The following is a description of a gene set: species: Homo sapiens Genes up-regulated in CD4 T cells: IL6 versus TGF beta and IL6. Human Gene Set: GSE21670_IL6_VS_TGFB_AND_IL6_TREATED_CD4_TCELL_UP from publication Durant L, Watford WT, Ramos HL, Laurence A, Vahedi G, Wei L, Takahashi H, Sun HW, Kanno Y, Powrie F, O'Shea JJ (PMID 20493732) STAT3, an essential transcription factor with pleiotropic functions, plays critical roles in the pathogenesis of autoimmunity. Despite recent data linking STAT3 with inflammatory bowel disease, exactly how it contributes to chronic intestinal inflammation is not known. Using a T cell transfer model of colitis we found that STAT3 expression in T cells was essential for the induction of both colitis and systemic inflammation. STAT3 was critical in modulating the balance of T helper 17 (Th17) and regulatory T (Treg) cells, as well as in promoting CD4+ T cell proliferation. We used chromatin immunoprecipitation and massive parallel sequencing (ChIP-Seq) to define the genome-wide targets of STAT3 in CD4+ T cells. We found that STAT3 bound to multiple genes involved in Th17 cell differentiation, cell activation, proliferation and survival, regulating both expression and epigenetic modifications. Thus, STAT3 orchestrates multiple critical aspects of T cell function in inflammation and homeostasis., and this is the list of marker genes: C3orf52, CREBRF, SLC66A1LP, FYB1, RPL12, LINC00189, FBXW8, GABRG1, GPR88, TRIT1, LBH, RPS25, STX17, COX7C, REG4, GABRB2, PITPNC1, DBI, PLIN3, ATP10A, THEMIS2, TPP2, PSMB1, SNRPE, MAN2A1, RASGRP2, ADSS2, IFITM2, RNF175, MICOS10, BAG3, PROX1, DGKA, ERP27, AAK1, PRKACB, RPL6, MIR30C1, UBASH3B, SNORD83A, NDUFV2, GPA33, PGGT1B, ACTL6A, EEF2KMT, LEF1, SCN10A, C1QBP, XYLB, CD48, RPS24, TEC, ADGRE1, GMFG, BCL9L, NOG, GLRX, SNORA55, SOD1, SYPL1, SLC20A2, RASGRF2, TUT4, COX6C, PACS1 (phosphofurin acidic cluster sorting protein 1), SLC39A10 (solute carrier family 39 member 10), RIPOR2, PDCD5, PYY, MGAT4A, RPS27, RPS27A, IFITM1, CELF2, ARHGEF11, UTP20, PLCL2, PAGE5, CCR7, RNF152, N6AMT1, SELL, TGFBR2, CXCL10, CRLS1, DYRK2, PEX7, TMEM272, SNORD41, PNO1, MAML2, SFPQ, TC2N, SIGLEC1, ATXN10, POLR1B, PAICS, BMP2K, SPG21, AGPAT5, ZNF507, PSMG2, SEMA3A, ADA2, PSMG4, HEBP1, COX16, RBFA, RPL23A, RCSD1, CFAP97, SULT1A2, TMEM37, ZYG11A (zyg-11 family member A, cell cycle regulator), MRPL3 (NCBI Gene Id 11222), NDUFB4, SGTB, STK38, MSR1, TMEM218, TRIB2, IFITM3, PLAC8, SPARCL1, SDK2, UQCRBP1, AOAH, RAB3GAP1, FUCA1, CD28, PHF7, ACTN1, MEF2A, GIMAP6, PRKCA, MDM4, MDS2, IL36A, ACY1, UBE3D, C16orf74 (NCBI Gene Id 404550), ATF6 (activating transcription factor 6), SDHC, OR1N1, RNU11, SPIRE2, USP3, LDLRAP1, CALB1, NLN, HSD17B11 (hydroxysteroid 17-beta dehydrogenase 11), UBR3, RAPGEF6, PFN2, SF1, FPGS (NCBI Gene Id 2356), C9orf72, CMTM7, GIMAP8, APBA2, IFNA5, ITGA6 (NCBI Gene Id 3655), CACUL1, MNT (NCBI Gene Id 4335), SERPING1, GCLC, GALR3, MLC1, MAS1L, NUAK2, ZNF800, SLC35E3, FCMR, RAB42, SULT1B1 (NCBI Gene Id 27284), CNIH2, CCDC85B, GTF3A, GIMAP2, NRIP1, NIT2, SLC36A2, CTSO, PMS1, TLR5 (toll like receptor 5), SLC16A10, RPL17, IPCEF1, DNAJB13, TCF7, FHIT, SHISAL2A